Given this list of marker genes ANO1, AEBP1 (AE binding protein 1), YY1AP1, HTRA1, ABCA1, MYH11, ABCG8, here is a description of the gene set: Human Gene Set: HP_CAROTID_ARTERY_STENOSIS Carotid artery stenosis species: Homo sapiens Narrowing of the carotid arteries.